Given this list of marker genes CDH6, USP48, TCF4, GCN1, PAXBP1, ZFHX3, SCG5, SOWAHC, UBN2, GCNT4, MED13L, AMMECR1L, SLCO3A1, TRIM67, PGA4, TSHZ1, CHRM3, BRINP1, HOXC13, SIRT2, CLSTN1, FGFR1, FOXI2, BAALC, PGA3, GLYAT, KCNK9, GIT2, TRIL, FIZ1, CCDC40, RERE, PGA5, MYO1C, NPIPB5, POU2F2, FAM167A, ARRDC4, SH3PXD2B, TBCK, FBP2, UBR3, KBTBD3, TIFAB, MEF2D, TMOD3, MLLT10, ASB15, LGR5, GRIN2A, NPIPB11, LHX9, PRRT1, TAB2, VWA8, BID, TGFB1I1, TMEM108, NFIX, NEK7, GPC4, here is a description of the gene set: from publication Chen Y, Wang X (PMID 31504780) studied in species Homo sapiens Genes predicted to be targets of miRBase v22 microRNA hsa-miR-6793-5p in miRDB v6.0 with MirTarget v4 prediction scores > 80 (high confidence targets). Human Gene Set: MIR6793_5P